The following is a description of a gene set: studied in species Mus musculus Mouse Gene Set: GOBP_MONOATOMIC_ION_HOMEOSTASIS Any process involved in the maintenance of an internal steady state of monoatomic ions within an organism or cell. Monatomic ions (also called simple ions) are ions consisting of exactly one atom., and this is the list of marker genes: Trf, Bsnd, Tmem94 (transmembrane protein 94), Cyp27b1, Ptk2, Atp1a3, Slc9a6, Tnfsf11, Tgfb2, Eif3e (NCBI Gene Id 16341), Car4, Pkd2, Mllt6, Egln1, Calm1, Chga, Slc11a1, Slc12a1, Atp1a2, Bola2, Cnr1, Sppl2c, Atp2a3, Creg1, Slc30a1, Osbpl2, Tbxas1, Atp2c1, Mettl21c, Grik2, Slc30a5, Slc24a3, Dmxl1, Hrc, Htr1b, Rmdn3, Ubash3b, C7, Trpa1, Gcm2, Prkca, Tmtc2, Ccl5, Rab7, Slc24a4, F2, Slc4a2, Ttpa, Tunar, Slc8a3, Slc39a13, Ntsr1, Tgm2, Slc9b2 (solute carrier family 9, subfamily B (NHA2, cation proton antiporter 2), member 2), Aco1, Atp7a, Mt2, Smdt1, Mir122, Xk, Neo1, Slc4a10 (solute carrier family 4, sodium bicarbonate cotransporter-like, member 10), Gp9, Tfr2, Sv2a, Atp4a, Atp6v1b1, Ccdc47, Atp12a, Snx10, Kl, Sypl2, Lck, Ap3b1, Slc4a4, Pdk4, Slc9a3, Slc12a5, Scnn1a, Kctd17 (potassium channel tetramerisation domain containing 17), Pacs2, Steap2, Atp13a4, Ednrb, Atp7b, Lrrk2, Hmox2, Wfs1, Anxa7, Fzd9, Scara5, Agt, Cckbr, Rab39, Slc39a14, Fbxl5, Plch2, Cnnm2, Csrp3, Dbi, Clic4, Smad1, Slc41a1, Ccl21d, Drd1, Fam20a, Slc31a2, Chd7, Nt5e, P2rx7, Ryr3, Atp6ap1, Fgfr1, Slc12a6, Mt1, Mir17, Tgfb1, Lime1, Gp1ba, Hcrtr1, Tmc6, Bnip3, Atp6ap1l, Tex101, Mcu, Trpc4 (transient receptor potential cation channel, subfamily C, member 4), Tesc, Atp1a1, Tmbim6, S100b, Pdzd8, Trpc5, Wnk1, Fto, Cav1, Dmd, Slc12a4, Ccl19 (C-C motif chemokine ligand 19), Nppc, Ext2, Tmc8, Dhrs7c, Pdpk1 (3-phosphoinositide dependent protein kinase 1), Cemip, Slc24a5, Kctd7, Atp2b3, Btbd9, Lcn2, Glp1r, Mafg, Cacna1d, Trim24, Kcnh1, Anxa6, 1600014C10Rik, Aqp11, Herpud1, Oca2, Iscu, Grn, Psen1, Hamp2, Gpr89, Cisd1, Immt, Hamp, Npsr1, Tm9sf4, Trpc2, Bak1, Cxcr3, Car12, Tnni3, Bax, Mecr, Fthl17e, Cacnb4, Grina, Slc25a27, Micu1 (NCBI Gene Id 216001), Atp4b, Atp6v0a2, Mapk1, Coro1a, Slc30a7, Lyn, Ednra, Cln5, Pln, Ireb2, Slc9a8, Slc39a9, Gsto1, Npy, Zng1, Bmp6, Cln3, Gstm7, Htr2c, Ccl19-ps5, Atp1b1, Slc1a1, Rab20, Slc9a1, Atp6ap2, Tmprss3, Slc12a7, Trp53, Sco1, Kcne3, Atp13a2, Hephl1, Wdr72, Atp2b1, Edn2, Ptk2b, Slc40a1, Corin, Chp2, Pde4d, Slc26a9, Sgk1, P2ry6, Nubp1, Fgfr3, Hps1, Tmem199, Upk3a, Cav3, Erc1, Plcb2, Kel, Flna, Tmem165, Slc9a9 (NCBI Gene Id 70648), Slc30a9, Plcg1, Sgcd, App, Prkce, Slc39a6 (NCBI Gene Id 106957), Mtss1 (MTSS I-BAR domain containing 1), Abl1, Prnd, Ncs1, Kcnq1, Rhd, Cdh23, Dmxl2, Minpp1, Hyal2, Pth1r, Slc11a2, Thy1, Cyp11b2, Kcna5, Kcnj16, Capn3, Atp6v0d1, Cul5, Slc9c1, Ube3a (NCBI Gene Id 76097), Atp6v0a4, Gdf2, Asph, Bdkrb1, Bmyc (brain expressed myelocytomatosis oncogene), Marcksl1, Slc12a3, Cacna1f, Ank, Cxcl11, Slc9a4, Itgav, Frrs1, Wnk3, Crh, Enpp1, Cib2, Tmem175, Otc, Ncoa4, Afg3l2 (NCBI Gene Id 69597), Rhag, Epas1, Cybrd1, Plcl2, Slc9a2, Gp1bb, Htr2b, Mon1a, Abcb6, Comt, Stim1, Trpv6, Il1a, Atp6v0a1 (NCBI Gene Id 11975), Stc2, Slc10a7 (solute carrier family 10 (sodium/bile acid cotransporter family), member 7), Ccl3, Scnn1g, Rogdi, Ddit3, Scn7a (sodium channel, voltage-gated, type VII, alpha), Pdk2, Ccl19-ps1, Slc34a1, Prkcb, Rnasek, Slc37a4, Slc30a8, P2ry1, Chp1, Slc24a2, Itpr3, Jsrp1, Car2, Fkbp1b, Micu3, Cox19, Slc39a10, Cnnm3, Sco2, Hfe, Tmem64, Prnp, Slc26a6, Cst5, Rhcg, Cox11, Grin1, Htr2a, Ifng, Rab38, Stc1, Gpr39, Slco2b1, Cox10, Ryr1, Commd1, Lamp1, Fth1, Picalm (phosphatidylinositol binding clathrin assembly protein), Vps54, Trmt10a (NCBI Gene Id 73171), Cps1, Slc12a9, Letmd1, Xcl1, Mfn2, Trpc3, Tspoap1, Casq1, Cd40, Ccr2, Mcur1, Cherp, Grid2ip, Cav2, Trpc1, Aplnr, Agtr1a, Nptn, Ccl19-ps3, Ttc7, Myh7b, Erfe (erythroferrone), Pik3cb, Nr3c2, Tmco1, Calb1, Ftmt, Fkbp1a, Ibtk, Tmem9, Akap6, Fech, Ccl21f, Snapin, Atg5, Ccr5, Bcl2, Snca, Atp13a5, Ccl19-ps6, Tmem38b, Kdr, Atp2b2, P2ry4, Trpv5, Ckb, P2ry2, Ccdc115, Car14 (NCBI Gene Id 99909), Plcl1, Steap4, Gper1, Ptprc, F2r, Sod1, Trpv4, Lhcgr, Umod, Tmem38a, Myc, Itpr2, Atp6v0d2, Trpc6, Abcc6, Eif2ak1, Cacna1c, Atp2c2 (ATPase, Ca++ transporting, type 2C, member 2), Ywhae, Cln6, P2rx2, Tfrc, Slc4a5, Atp2b4, Atp2a1, Ptpn6, Cftr, Drd4, Hvcn1, Vps33a, Cd19, Slc39a8, Pkhd1, Sri, Ryr2, Spx, Cnnm1, Thada, Myo5a, Pthlh, Aplp2, Tpcn2, Slc39a7, Tcirg1, Ccl21b, Mt3, B2m, Calcb, Atf4, Edn1, Grin2b, Ccdc22, Slc26a3 (NCBI Gene Id 80590), Xcr1, Cxcl9, Arf1 (NCBI Gene Id 11840), Steap3, Tmtc4, Fgf23 (fibroblast growth factor 23), Slc31a1, Tmem106b, Ank1, Spns1, Avp, Glrx3, Dmtn, Slc4a7, Slc4a8, Spp1, Clec4b1, Slc25a23, Ccl19-ps4, P2rx1, Mt4, Slc8a2, Micu2, Vdr, Atp13a1, Cxcl10, Slc45a2, Sod2, Hjv (hemojuvelin BMP co-receptor), Mapk3, Slc24a1, Synpo, Cacna1a, Inpp4b, Atp1b3, Slc8b1, Disc1, Efhc1, Tasl, Pml, Plcd1, Atp6v1b2, Ero1a, Jph2, Ccl21e (C-C motif chemokine ligand 21E), Slc4a9, Abcb7, Slc8a1, Tmem178, Erc2, Rap1gds1, Kcnma1, Plcb4, Epb42, Dmpk, Lacc1, Lcn6, Trdn, Ext1, Cp, Bok, Atp2a2 (ATPase, Ca++ transporting, cardiac muscle, slow twitch 2), Slc9b1, Stoml2, F2rl3, Unc80, Dbndd2, Clcnkb, Kcnh2, Cx3cl1, Selenon, Atp6v0c, Slc39a4, Ank3, Slc35g1, Fxn, Calb2, Ankrd9, Pth, Kcna1, Tmem203, Cdh5, Tmprss6, Hexb, Ccl2, Cib3, Prkd1, Casr, Fxyd2, Ccr1, Atp6v1a, Fam3a, Slc4a11, Kcnj10, Wnt5a, Scnn1b, Letm1, Gpr12, Adcy8, Trpm7, Nol3, Plch1, Slc12a2, Grm1, Ccl8, Rimbp2, Trpm8, Atp1b2, Cnga1, Psen2, Adora1, Npy1r, Alas2, Sv2b, Slc1a3, Atp1a4, Vapb, Fcrl5, Htt, Cyb561, Plcb3, Plcb1 (NCBI Gene Id 98861), Cacna1s, Hap1, Slc39a12, Ccr1l1, Hoxa3, Hif1a, Abcc2, Mtln, Slc9a5, Atp6v1g1, Casq2, Gp5, Slc4a3, Stim2, Atox1, Heph, Alpl, Plcg2, Smad4, Drd2, Avpr1a, Camk2d, Jph3, Fasl, Hcrtr2, Ms4a2 (membrane-spanning 4-domains, subfamily A, member 2), Selenok, Atp5f1b, Drd3, Car7, Pygm, Mcoln1, Smad5, Slamf8, Calm2, Hpx, Stk39, Atp13a3, Gpr3, Ndfip1, Calm3, Slc26a4, Wnk4, Meltf, Cdk5, Edn3, Il13, Nucb2, Cyb561a3, Ctrc, Mc3r, Clcc1, Ank2, Fxyd1, Rgn, Slc4a1, Naglu, Ghitm, Diaph1, Agtr2, Calca, Cngb1 (cyclic nucleotide gated channel beta 1), Klhl3, Slc30a10, Ngf, Slc39a5, Cnnm4, Frey1, Fate1, Plce1, Trpm2, Acvr2b, Hmox1, Wnk2, Itgb3, Itpr1 (NCBI Gene Id 18544), Maip1, Znhit1, Cyba, Lamp2, Clstn1, Ccl21a, Fgf2, Ppt1, Apoe, Slc9a7, Slc12a8, Trpc7 (transient receptor potential cation channel, subfamily C, member 7), Ftl1, Cacnb2, Mcub, Slc30a2